Given this list of marker genes CBR1, NEDD9, KBTBD7, SHE, MYF6, KREMEN1, PLCG1, BNIP5, LURAP1 (NCBI Gene Id 541468), PERP, ARMC3, COPRS, PNPLA8, ZNF451, MED22, RGS7, IMMP2L, SLC39A6 (solute carrier family 39 member 6), GSN, SLC25A46, TMEM190, DDX5 (NCBI Gene Id 1655), TOP3B, ATG12, NAALADL2, UNC93B1, LONP2, PRND, NOVA2, RPAP3, TP53I13, TMED6, CD83, SLC35F5, HYAL3, HNRNPF, AGRN, DPP7, CSTF2, AFG3L2, CLYBL, PAG1, STXBP4, PHKB, CCDC167, TRIAP1, MBNL1, USP3, LRRC10B (NCBI Gene Id 390205), ACER3, SPAG9, OSBPL8, ZNF8, ATRX, TMPRSS4, SPACA1, NKX1-2, TMED10, STRN, SLC27A1, CPSF3, PRKAR2A, POT1, MED29, DRD2, ZPBP2, ITGB5, MYPOP, RAP1A, BCL2L2, EEF1AKMT2, NT5DC1, RDH16, RUNDC3B, ZDHHC23, USP33, LINC00301, MICU3, RPH3A, RPGR, MATN1, CFB, SGF29, ABHD13, CLEC4G, CNGB3, MDFIC, TPD52 (NCBI Gene Id 7163), STARD4, MPZL2, RANBP6, SGSH, SERF2, OSBPL7, NID1, POLR3G, SPDYE18, ZDHHC14, GSTK1, CTRC, MOSPD2, PRR13, VPS13A, SYBU, ATE1, BMP2, CCDC181, MYOZ3, TSTD2 (thiosulfate sulfurtransferase like domain containing 2), PYGL, CYP2D6, NKIRAS1, IRX5, TBK1, SLC41A2, CD72, MMP10, SEPTIN10, BRWD3, TRIM59, DRG1, EPCAM, C1orf174, NINL, PDE4DIP (NCBI Gene Id 9659), SLC9A9, DCBLD1, STXBP3, PHTF2, GRPEL2, TPP1, PFKFB1, ERLIN2, DRC3, ZAP70, MAN1A1, HGFAC, VPS26A, PDE1C, PRAMEF25, MYL4, PTPN14, CELF2, C1GALT1, DPY19L3, ALX4, AMN1, SLC39A13, BMP2K, PIGN, RBM4B, FRS3, RBM10, TFEC, ADGRD1, TRAPPC11, HACE1, SEC14L2, CCDC85A, ANXA4, TSPAN15 (tetraspanin 15), SQOR, TRA2A, KDM6A, CD84, ITGAV, IL1RAPL1, RPL39L, SERINC4, DOK1, TMF1, OPTN, EAF2, SFT2D1, SCN4B, AKAP6, SLC38A4, PLEKHM1, STRN4, PITPNM1, MS4A7, IMPA1, ALKBH3, NAB1, ZNF180, STAP2, TDRD1, MPEG1, POU4F3, TMED8, KLHL8, UGDH, CNGA1, WBP2NL, MTMR9, ENPP6, TNS4 (NCBI Gene Id 84951), ABHD17A, here is a description of the gene set: studied in species Homo sapiens from publication Lin W, Haribhai D, Relland LM, Truong N, Carlson MR, Williams CB, Chatila TA (PMID 17273171) Human Gene Set: GSE6875_TCONV_VS_TREG_UP To analyze gene expression in in regulatory T cell precursors that develop in the absence of a functional Foxp3 protein as compared to that of normal regulatory T cells Genes up-regulated in T conv versus T reg.